The following is a description of a gene set: species: Homo sapiens Genes up-regulated in HEK293 cells at 2h after stimulation by muramyl dipeptide: over-expressing wildtype NOD2 versus control. Human Gene Set: GSE22611_NOD2_TRANSDUCED_VS_CTRL_HEK293T_STIMULATED_WITH_MDP_2H_UP NOD2 is an intracellular receptor for the bacterial cell wall component muramyl dipeptide (MDP) and variants of NOD2 are associated with chronic inflammatory diseases of barrier organs e.g. Crohn disease, asthma and atopic eczema. It is known that activation of NOD2 induces a variety of inflammatory and antibacterial factors. The exact transcriptomal signatures that define the cellular programs downstream of NOD2 activation and the influence of the Crohn-associated variant L1007fsinsC are yet to be defined. To describe the MDP-induced activation program, we analyzed the transcriptomal reactions of isogenic HEK293 cells expressing NOD2wt or NOD2L1007fsinsC to stimulation with MDP. Importantly, a clear loss-of-function could be observed in the cells carrying the Crohn-associated variant L1007fsinsC, while the NOD2wt cells showed differential regulation of growth factors, chemokines and several antagonists of NF-κB, e.g. TNFAIP3 (A20) and IER3. from publication Billmann-Born S, Till A, Arlt A, Lipinski S, Sina C, Latiano A, Annese V, Häsler R, Kerick M, Manke T, Seegert D, Hanidu A, Schäfer H, van Heel D, Li J, Schreiber S, Rosenstiel P (PMID 21335489), and this is the list of marker genes: RNF166, TNFRSF14, RCAN2, FAM3A, DLGAP4, DAP (NCBI Gene Id 1611), TAC4 (tachykinin precursor 4), STING1, MEF2C, CMPK2, HEXIM2, TMEM184B, KDM5B, COMMD7, GFI1B, CAPN10, CROT, IFIT2, EVL, EIF2AK3, PDLIM7, CD93, ABCA1, ATF7IP (NCBI Gene Id 55729), ATP6V0B, DPP7, SHISA5, SGMS1, SGK1, TXNL4B, TMBIM6, DOCK8 (dedicator of cytokinesis 8), SEMA4B, SLC46A3, RAC2, RELN, PFN2, LAMTOR3, EYA1, PTGER4, PGGHG, HIVEP1, NRBP1, SUSD1, MDFIC, SOX4, ARHGAP24, CD22, BCAS3, IKZF3, GNG2, ABLIM1, AP1M1, ATP6V1B2, MYO1D, CST3 (NCBI Gene Id 1471), ING4, GBP4, PEX5, PIP4K2C, USB1, RIGI, ATP6V0C, AGPAT3, SLC12A6, TCP11L2, ZDHHC9, ADGRE5, SNRK, CPEB4, LYN, RAB11B, RNF122 (NCBI Gene Id 79845, ring finger protein 122), BMAL1, ST8SIA4, FAM20B, ELF1, ANXA11, EGR2, STAM, STX5, MTF1, PLEKHF2 (NCBI Gene Id 79666), NCOA1, MAP1LC3B, RABEP2, BIRC3, N4BP2L1, RETREG2, LAPTM5, FOXP1, IRAK4, CNOT6L, RFK, RBM43, LAMP1, RAB5B (NCBI Gene Id 5869), GLCCI1, FAM8A1, DHRS3, SLC25A51, GAB2, PPP1R16A, PLCB2, OSTM1, TOLLIP, SCAMP2, TAX1BP3, PPP1R16B, MIDN, CORO7, BCL7B, PXN, CELF2, USE1, CRAT, BMPR2 (NCBI Gene Id 659), GMFG, KLF3, PARP8, ITGAL, PTPN7, COMMD8, FCRL1, CERK, GPR18, NME3, IRF8 (interferon regulatory factor 8), TMEM132E, ZNF496, DVL3, RHOBTB2 (Rho related BTB domain containing 2), EGR1, PXMP4, PHACTR1 (NCBI Gene Id 81705), DIO2, GIMAP6, SESN3, NEU1 (neuraminidase 1), TCN2, HIPK3, GNS (glucosamine (N-acetyl)-6-sulfatase), PTPN6, SIRT2, ULK1, ACOX3, ADAM10, TXNDC15, HYAL3, COMMD4, NXPE4, ABCB4, CPM, FLCN, SNAP29, ST3GAL1, YIPF3, PHKA1, MYB, PTGR1, NT5C2 (5'-nucleotidase, cytosolic II), DAXX, TMEM127, RNF14, SPNS1, IRF2, GNAO1, LRRC57, RAD9A, MXD1, ITGB2, INPPL1, SERP1, LSP1, CCR7, COBLL1, HDAC1